The following is a description of a gene set: studied in species Homo sapiens Human Gene Set: REACTOME_PLATELET_CALCIUM_HOMEOSTASIS Platelet calcium homeostasis, and this is the list of marker genes: TRPC3, ATP2A1, ATP2A2 (ATPase sarcoplasmic/endoplasmic reticulum Ca2+ transporting 2), TRPC6, ATP2B3, SLC8A3, ATP2B1, P2RX7, ITPR2 (NCBI Gene Id 3709), SRI, STIM1, ITPR3, CALM1, P2RX2 (NCBI Gene Id 94142), ATP2B4, ORAI2, P2RX5, P2RX4, P2RX6, P2RX3, TRPC7, ATP2A3, SLC8A2, ORAI1 (ORAI calcium release-activated calcium modulator 1), ITPR1, SLC8A1, P2RX1, ATP2B2